Given this list of marker genes SCN9A, CACNB2, GJA5, FLNA, KCNH2, MIR448, KCNJ2, SCN1B, PKP2, PDE4B, RNF207, MIR1-1, SCN11A, STC1, SNTA1, SCN1A, SLC9A1, MYBPC3, KCNJ8, CACNA2D1, KCND3, JUP, DSP, CAV3, GPD1L, CAMK2D (NCBI Gene Id 817), SCN2B, DSC2, FGF12, SCN10A, ATP1A2, ATP2A2, DLG1, KCNE3, PLN, PIK3CA, ANK2, STRIT1, NEDD4L, KCNE1, NOS1AP, CACNA1C, KCNE4, GSN, KCNA5 (potassium voltage-gated channel subfamily A member 5), CTNNA3, NUP155, ABCC9, KCNE5, AKAP9, SGCD, CAV1, CACNA1G, SRI, KCNE2, PDE4D, TNNC1, KCNJ5, GJA1, C10orf71, RANGRF, CACNA1D, BIN1, KCNJ3, CASQ2, MYH7B, HCN4, SCN4B (sodium voltage-gated channel beta subunit 4), SCN3A, ATP1A1, DSG2, KCNN2, SCN5A, RYR2, ADORA1, NOS1, TRPM4, ADCY10, KCNQ1, FGF13, SCN2A, SCN4A, MIR133A1, GATA4, ATP2A1, MIR328, SCN3B, SCN7A, SUMO1, SCN8A, GJC1, here is a description of the gene set: Human Gene Set: GOBP_CARDIAC_MUSCLE_CELL_CONTRACTION species: Homo sapiens The actin filament-based process in which cytoplasmic actin filaments slide past one another resulting in contraction of a cardiac muscle cell.